Given this list of marker genes Map2 (microtubule-associated protein 2), Trim46, Mecp2, Kif1c, Kif1b, Kif1a, Sybu, here is a description of the gene set: Mouse Gene Set: GOBP_ANTEROGRADE_NEURONAL_DENSE_CORE_VESICLE_TRANSPORT The directed movement of substances in neuronal dense core vesicles along axonal microtubules towards the presynapse. species: Mus musculus